Given this list of marker genes CEBPB (CCAAT enhancer binding protein beta), TSPAN3, SSPN, TAGLN2, FTH1, MECP2 (NCBI Gene Id 8274), ADGRE2, ANG, CCNA1, CD14, KIAA0040, R3HDM2, TRIM9, NELFE, ALDH2, HSD17B6, ANXA4 (NCBI Gene Id 307), TBK1, RALB, APOO, LAT2, F3, CDS2, ATP6V1B2, MYRF, MAST1, LAP3, MIR22HG, DSCAM, CLN8, SAT1, DAG1, CARS1, COX5B, RNF24, MNS1, ETV3, CARMIL1, RPS6KA2, ACVR1B, SIRT7, TNFSF10, DUSP6, IL1RN, TNFAIP6, STYXL1, NCF1C, GRP (NCBI Gene Id 2922), EFCAB2, GTF2IRD1, SLC25A14, NRG1, ZPR1, SH3BP5, CLIC4 (NCBI Gene Id 25932), VPS39, TGIF1, NPC1, TARS1, SLC6A12, AHCYL1, LMO4, CPD, MTHFD2, EXOC6B, S100A13, ASGR1, SLC1A5, RGS3, PHF7, CYRIA, ECI1, IQSEC1, SH3GLB1, SLC30A1, GK, EXPH5, SAV1, KCTD5, DNAAF1, CST6, GBP2, INPP5F, PEX19, IMPA2, KIAA0513, TSC22D1 (NCBI Gene Id 8848), STX4 (syntaxin 4), SPATA31C2, MTHFS, DSP, SLC30A3, KYNU, CTTN, HDAC9, C1S, POLR3D, ADIPOR1, EML1, RMC1, ATP6V1H, BACH1, LMAN2, HOMER1, PDE4DIP, C5AR2, TIMP2, GLRX2, SQSTM1, AARS1, PSMB9, ST3GAL5, RHBDF1, CKAP4, MSRB1, PSTPIP2, NACC2, ABHD5, ATP1B3, LRRC8B, TEX264, SERPINI1, SUSD6, CAMSAP2, PSMA6, PCK2, NFE2L1, CD72, INSR, C3, PTAFR, SQOR, B9D2, CFB, GBP1, IFNA21, TBL1X, RRAD, MYOF, ATF3, KLHL18, TXNRD1, LCMT1, CD86, SPAG9, DCHS1, LILRA2, GPC4, BCL2A1, SIGLEC6, RNF128, HPD, CTSV, PHGDH (phosphoglycerate dehydrogenase), PGD, ZMYND8, HLA-F, EGR2, RCN1 (reticulocalbin 1), HSPBAP1, DOCK4, ASNS (asparagine synthetase (glutamine-hydrolyzing)), NCF2, SARS1, CYP27B1, DHRS9, LRRFIP2, SPATS2L, INHBE, APOL1, LYN, VPS9D1, FST, TLR1, ELOVL1, DOP1B, TMEM43, SYNC, SCG5, NIBAN1, GREM1, TNFSF14, IFIT3, RALA, FZD1 (NCBI Gene Id 8321), SHMT2, RGCC, AP3S2, VPS11, CTNND2, PSMB10, SLC43A3, ATP6V1E1, RAB13, CEBPG, LONP1, WARS1, IGFBP6, JAK2, IL6R, here is a description of the gene set: studied in species Homo sapiens from publication Prots I, Skapenko A, Lipsky PE, Schulze-Koops H (PMID 21347372) Human Gene Set: GSE24634_IL4_VS_CTRL_TREATED_NAIVE_CD4_TCELL_DAY7_DN Genes down-regulated in comparison of CD25- T cells treated with IL4 at day 7 versus untreated CD25- T cells at day 7. CD25+ regulatory T cells develop in the thymus (nTregs), but may also be generated in the periphery upon stimulation of naive CD4 T cells under appropriate conditions (iTregs). The mechanisms that regulate the generation of peripheral iTregs are largely unknown. We used microarrays to gain insights into the molecular program of extrathymic Treg development.